The following is a description of a gene set: Any process that increases the rate, frequency or extent of nitric oxide mediated signal transduction. Nitric oxide mediated signal transduction is The series of molecular signals mediated by the detection of nitric oxide (NO). Human Gene Set: GOBP_POSITIVE_REGULATION_OF_NITRIC_OXIDE_MEDIATED_SIGNAL_TRANSDUCTION studied in species Homo sapiens, and this is the list of marker genes: GUCY1A2, INS, GUCY1A1, KDR (kinase insert domain receptor), SCARB1